Given this list of marker genes AKR1C3, HSD17B6, AKR1B15, DHRS1, DHRS11, HSD17B3, AKR1C1, AKR1C4, HSD17B1, here is a description of the gene set: Human Gene Set: GOMF_17_BETA_HYDROXYSTEROID_DEHYDROGENASE_NADPPLUS_ACTIVITY studied in species Homo sapiens Catalysis of the reaction: a 17-beta-hydroxysteroid + NADP+ = a 17-oxosteroid + NADPH + H+.